Given this list of marker genes Guca2a, Rarg, Alox5ap, Lama3 (NCBI Gene Id 16774), Caap1, Calml3, Il36b, Fpr3, Tradd (NCBI Gene Id 71609), Cxcl1, Sprr2g, Ahnak, Ero1a, Ces2g, 1600010M07Rik, Sprr2i, Ncf2, Ighd, Plaur, Spp1, Mustn1, here is a description of the gene set: Mouse Gene Set: MATTHEWS_SKIN_CARCINOGENESIS_VIA_JUN Activation of activator protein 1 (AP-1) and nuclear factor kappaB (NFkappaB)-dependent transcription is required for tumor promotion in cell culture models and transgenic mice. Dominant-negative c-Jun (TAM67) blocks AP-1 activation by dimerizing with Jun or Fos family proteins and blocks NFkappaB activation by interacting with NFkappaB p65. Two-stage skin carcinogenesis experiments in a model relevant to human cancer risk, transgenic mice expressing human papillomavirus 16 E7 oncogene (K14-HPV16-E7), show E7-enhanced tumor promotion. A cross to K14-TAM67-expressing mice results in dramatic inhibition of tumor promoter-induced AP-1 luciferase reporter activation and papillomagenesis. Epithelial specific TAM67 expression inhibits tumorigenesis without affecting TPA- or E7-induced hyperproliferation of the skin. Thus, the mouse model enriches for TAM67 targets relevant to tumorigenesis rather than to general cell proliferation or hyperplasia, implicating a subset of AP-1- and/or NFkappaB-dependent genes. The aim of the present study was to identify target genes responsible for TAM67 inhibition of DMBA-TPA-induced tumorigenesis. Microarray expression analysis of epidermal tissues revealed small sets of genes in which expression is both up-regulated by tumor promoter and down-regulated by TAM67. Among these, cyclooxygenase-2 (Cox-2/Ptgs2) and osteopontin (Opn/Spp1) are known to be functionally significant in driving carcinogenesis. Results identify both Cox-2 and Opn as transcriptional targets of TAM67 with CRE, but not NFkappaB sites important in the Cox-2 promoter and an AP-1 site important in the Opn promoter. from publication Matthews CP, Birkholz AM, Baker AR, Perella CM, Beck GR Jr, Young MR, Colburn NH (PMID 17363560) Genes up-regulated by skin tumor promoters but completely blocked by expression of TAM67, a dominan-negative form of JUN. studied in species Mus musculus